The following is a description of a gene set: from publication Nutt CL, Mani DR, Betensky RA, Tamayo P, Cairncross JG, Ladd C, Pohl U, Hartmann C, McLaughlin ME, Batchelor TT, Black PM, von Deimling A, Pomeroy SL, Golub TR, Louis DN (PMID 12670911) In modern clinical neuro-oncology, histopathological diagnosis affects therapeutic decisions and prognostic estimation more than any other variable. Among high-grade gliomas, histologically classic glioblastomas and anaplastic oligodendrogliomas follow markedly different clinical courses. Unfortunately, many malignant gliomas are diagnostically challenging; these nonclassic lesions are difficult to classify by histological features, generating considerable interobserver variability and limited diagnostic reproducibility. The resulting tentative pathological diagnoses create significant clinical confusion. We investigated whether gene expression profiling, coupled with class prediction methodology, could be used to classify high-grade gliomas in a manner more objective, explicit, and consistent than standard pathology. Microarray analysis was used to determine the expression of approximately genes in a set of 50 gliomas, 28 glioblastomas and 22 anaplastic oligodendrogliomas. Supervised learning approaches were used to build a two-class prediction model based on a subset of 14 glioblastomas and 7 anaplastic oligodendrogliomas with classic histology. A 20-feature k-nearest neighbor model correctly classified 18 of the 21 classic cases in leave-one-out cross-validation when compared with pathological diagnoses. This model was then used to predict the classification of clinically common, histologically nonclassic samples. When tumors were classified according to pathology, the survival of patients with nonclassic glioblastoma and nonclassic anaplastic oligodendroglioma was not significantly different (P = 0.19). However, class distinctions according to the model were significantly associated with survival outcome (P = 0.05). This class prediction model was capable of classifying high-grade, nonclassic glial tumors objectively and reproducibly. Moreover, the model provided a more accurate predictor of prognosis in these nonclassic lesions than did pathological classification. These data suggest that class prediction models, based on defined molecular profiles, classify diagnostically challenging malignant gliomas in a manner that better correlates with clinical outcome than does standard pathology. Top 50 marker genes for glioblastoma multiforme (GBM), a class of high grade glioma. Human Gene Set: NUTT_GBM_VS_AO_GLIOMA_UP studied in species Homo sapiens, and this is the list of marker genes: DYNLT3, GAP43, STAT1, CAP1, ITGB4, CAPNS1, PLEKHM2, ANXA2, TMED9, FZR1, DDOST (NCBI Gene Id 1650), FADS3, SMOX, CAPZB, PIK3R2, TP53BP2, LRRC41, MAOB, HIPK1, LAMB2, DCTD, NUCB1, AP1S2, LHFPL2, AQP4, TMEM109, GALNT2 (NCBI Gene Id 2590), RBBP4, HLA-F, AGL, RHOC, GPI, BTN3A2, TAGLN2, CD74, MSN, CHL1, TMX1, SH3GLB1, CLIC4, IGFBP5, LDHA (NCBI Gene Id 3939), VIM, LAPTM5, FLNA, CLIC1